Given this list of marker genes Gtf2h2, Tex24, Cdk9, Rb1, Gtf2f2 (general transcription factor IIF, polypeptide 2), Ccnc, Cdk12, Cdk13, Bccip, Ccnt2, Gtf2h4, Ccnt1, Psmc5, Ccnh, Brd4, Snw1, Cdk7, Cdk8, Gtf2h1, Ccnk, Med13, Ercc3, Ercc2, Mnat1 (NCBI Gene Id 320958), Med12, Gtf2h3, Gtf2h5, here is a description of the gene set: Cyclin-dependent protein kinase (CDK) complex found in the nucleus. Mouse Gene Set: GOCC_NUCLEAR_CYCLIN_DEPENDENT_PROTEIN_KINASE_HOLOENZYME_COMPLEX species: Mus musculus